Given this list of marker genes Map1b, L1cam, Dbnl, Rufy3, Twf2, Anapc2, Adnp, Rpl4, Zfyve27 (NCBI Gene Id 72352), Bmpr2, Smurf1, Cyfip1, Lrp1, Eif2b2 (eukaryotic translation initiation factor 2B, subunit 2 beta), Apoe, Fn1, Pou4f2, Trpc5, Nrp1, Megf8, Cdh4, Sema7a, Srf, Islr2, Vegfa, Map3k13, Sema5a, Cdkl5, Ngf, Ilk, Ntrk3, Golga4, Tnfrsf12a, Eif4g2, Ntn1, Gdi1, Shtn1, Pafah1b1, Cxcl12, Myo5b, Trpv2 (transient receptor potential cation channel, subfamily V, member 2), Adcy10, Limk1, Fxn (NCBI Gene Id 14297), Ndel1 (NCBI Gene Id 83431), Mapt, Disc1, Arhgap32, Bdnf, Gsk3b, Ep300, Macf1, Dscam, Pak1, Dbn1, here is a description of the gene set: Mouse Gene Set: GOBP_POSITIVE_REGULATION_OF_AXON_EXTENSION Any process that activates or increases the frequency, rate or extent of axon extension. studied in species Mus musculus